Given this list of marker genes Slc44a2 (solute carrier family 44, member 2), Scn4a, Slc22a2, Sec14l1, Slc44a1, Slc5a7, Slc44a4, Slc44a5, Flvcr2, Psen1, Flvcr1, here is a description of the gene set: species: Mus musculus Mouse Gene Set: GOBP_CHOLINE_TRANSPORT The directed movement of choline into, out of or within a cell, or between cells, by means of some agent such as a transporter or pore. Choline (2-hydroxyethyltrimethylammonium) is an amino alcohol that occurs widely in living organisms as a constituent of certain types of phospholipids and in the neurotransmitter acetylcholine.